The following is a description of a gene set: Human Gene Set: MIR4665_5P Genes predicted to be targets of miRBase v22 microRNA hsa-miR-4665-5p in miRDB v6.0 with MirTarget v4 prediction scores > 80 (high confidence targets). studied in species Homo sapiens from publication Chen Y, Wang X (PMID 31504780), and this is the list of marker genes: GIMAP1, ISL1, PCDHGB7, SPTAN1, HNRNPAB, TTC39C (NCBI Gene Id 125488), SLC30A7, REG3A, BRWD3, UBE2Z, CCDC148 (coiled-coil domain containing 148), RAB3A, PINX1, ENY2, HMGB3, NFIX, CLEC2D, PCDHGA9, TTC17, CTBS (NCBI Gene Id 7811), POU3F2, CACNA1C, GRIK2, IGF2, TACR1, PPM1E, PCDHGA2, SEC24A, ZNF629, ZNF131, ARRB1, ZDHHC15, DDX17, SIRT2, SDCBP2, ZBTB7A, SPRED3, SAMD4B, MPZL2, KRT23, SLC2A4RG, SLC25A42, ATP10B, STX8, ZNF32, WIZ, LEFTY2, CCDC33, SHISAL1, LZTS3, ASB11, CASKIN2, OVOL2, NXPH2, KCTD20, IGF2BP3, FOXP4, NOS1, PCDHGA10, PPP1R3C, SOX7, SPICE1, KLHL28 (kelch like family member 28), PKNOX2 (PBX/knotted 1 homeobox 2), PPT2, SPIDR, NKAPL, IP6K3, FBN1, DVL3, CASTOR2, SPINT1, MAPK4, PRKCA, KCNJ10, SPAG9, PTGER3, NOVA2, PHYH, RDX, PCDHGA5, ATCAY, CBX6, BHLHE41, WASHC4, SPEN, ACTB, LPCAT3, SERTAD2, GANAB (glucosidase II alpha subunit), RAB3B, UPK2, PCDHGA8, SENP6, CFAP418, LALBA, SLC10A2, DCLK1, NALF2, PAX5, WDHD1, CEBPG, ZSWIM4, VPS37D, GATAD2B, IGF1, RPAIN, ABCF1, RAB11FIP5, PCDHGA12, ELOVL2, SSX2IP, RNF10, FOXA3, G3BP2, ADAR, PCDHGB3, AKNAD1, PCDHGA3, FAM50B, TM9SF2, SLC7A8, PIGG, SUCNR1, PPP2R2D, LRRC28, MECP2, TLNRD1, C12orf75, PCDHGC3, CBLN1, PCDHGA11, JAZF1, OTOR, RABGGTB, ZNF444, ZFP36L2, NAALADL2, PCDHB13, CTNND2, KSR2, SHISA7, SIAH1, PCDHGA7, MAJIN, THUMPD2, MYCT1, APLNR, SSC4D, SLC6A17, SYNPR, PCDHGA1